Given this list of marker genes Cldn5, Slit2, Pde2a, Abcc8, Abr, C2cd4a, Adm, Bmp6, Ceacam1, Fgfbp3 (NCBI Gene Id 72514), Arhgap35, Fermt2, Cxcr2, Ocln, Adora2a, Amot, Ifnb1, Ddah1, Zeb2, Ctnnbip1, Tacr1, Ccl4, Il18, Tjp2, Tgfb1, C2cd4b, Bcr, Nr3c1, Akap12, Trpv4, Cdh5, Tjp1, Gpr4, Capn1, Tjp3, Sh3gl2, Ptprj, Tacr2, Angpt1, Plec, Pde3a, Hrh1, Vegfa, Plvap, Ptp4a3, Apoe, Mylk3, Ucn, Ramp2, here is a description of the gene set: Any process that modulates the extent to which blood vessels can be pervaded by fluid. species: Mus musculus Mouse Gene Set: GOBP_REGULATION_OF_VASCULAR_PERMEABILITY